Given this list of marker genes XRCC6, ANXA8, DNAJC7, HSD17B4 (hydroxysteroid 17-beta dehydrogenase 4), CKS2, PNN, ACAA2, CBX1, EMG1, MMD, MARK3, LMO4, JCHAIN, SRP72, UBB, ANXA3, AIMP2, SALL2, CAPZA2, GGH, KRT18, LAMB1, PSMD4, CSE1L, KRT19, CXADR, ACADM, LDHB, SET, POLD2, TNFRSF1A, NDUFS8, PUDP, DCUN1D4, SHROOM2, GBA1, GALE, RBBP7, HNRNPM, ELF2, GMFB, SRI, ARL4D, BIRC3, HOXB7, GCSH, SAFB, SULT1A3, RBBP4, GOLGA1, DUSP4, GTF2B, AHCY, RAB11A, RAE1, TBCE, SLC4A2, ATP1B1, KRT8, CAPG, KRT7, TSPAN3, CCNE1, SEPHS2, RBM39, FLII, QARS1, SPEG, PROCR, here is a description of the gene set: studied in species Homo sapiens from publication Ouellet V, Provencher DM, Maugard CM, Le Page C, Ren F, Lussier C, Novak J, Ge B, Hudson TJ, Tonin PN, Mes-Masson AM (PMID 15940270) Genes up-regulated in pirmary cultures of epithelial ovarian cancer (EOC): invasive (TOV) vs low malignant potential (LMP) tumors. Tumors of low malignant potential (LMP) represent 20% of epithelial ovarian cancers (EOCs) and are associated with a better prognosis than the invasive tumors (TOV). Defining the relationship between LMPs and TOVs remains an important goal towards understanding the molecular pathways that contribute to prognosis, as well as providing molecular markers, for these EOCs. To this end, DNA microarray analyses were performed either in a primary culture or a tumor tissue model system and selected candidate genes showing a distinctive expression profile between LMPs and TOVs were identified using a class prediction approach based on three statistical methods of analysis. Both model systems appear relevant as candidate genes identified by either model allowed the proper reclassification of samples as either LMPs or TOVs. Selected candidate genes (CAS, CCNE1, LGALS8, ITGbeta3, ATP1B1, FLIP, KRT7 and KRT19) were validated by real-time quantitative PCR analysis and show differential expression between LMPs and TOVs. Immunohistochemistry analyses showed that the two tumor classes were distinguishable by their expression of CAS, TNFR1A, FLIP, CKS1 and CCNE1. These results define signature patterns for gene expression of LMPs and TOVs and identify gene candidates that warrant further study to deepen our understanding of the biology of EOC. Human Gene Set: OUELLET_CULTURED_OVARIAN_CANCER_INVASIVE_VS_LMP_UP